The following is a description of a gene set: studied in species Homo sapiens Human Gene Set: YANG_BREAST_CANCER_ESR1_DN from publication Yang F, Foekens JA, Yu J, Sieuwerts AM, Timmermans M, Klijn JG, Atkins D, Wang Y, Jiang Y (PMID 16261164) Genes down-regulated in early primary breast tumors expressing ESR1 vs the ESR1 negative ones. About 70-80% of breast cancers express estrogen receptor alpha (ER-alpha), and estrogens play important roles in the development and growth of hormone-dependent tumors. Together with lymph node metastasis, tumor size, and histological grade, ER status is considered as one of the prognostic factors in breast cancer, and an indicator for hormonal treatment. To investigate genes and pathways that are associated with ER status and epithelial cells in breast tumor, we applied laser capture microdissection (LCM) technology to capture epithelial tumor cells from 28 lymph node-negative breast tumor samples, in which 17 patients had ER-alpha+ tumors, and 11 patients have ER-alpha- tumors. Gene expression profiles were analysed on Affymetrix Hu133A GeneChip. Meanwhile, gene profiles using total RNA isolated from bulk tumors of the same 28 patients were also generated. In total, genes and genes with significant P-value and having significant differential expression between ER-alpha+ and ER-alpha- tumors were identified from the LCM data set and bulk tissue data set, respectively. A total of genes were found to be common in both data sets, while genes were unique to the LCM data set and genes were present only in the bulk tumor data set. Pathway analysis with the genes using Gene Ontology suggested that genes involved in endocytosis, ceramide generation, Ras/ERK/Ark cascade, and JAT-STAT pathways may play roles related to ER. The gene profiling with LCM-captured tumor cells provides a unique approach to study epithelial tumor cells and to gain an insight into signaling pathways associated with ER., and this is the list of marker genes: SLC25A37, FABP5, YEATS2, RAP2B, SFRP1, LDHB, SLC9A6, GABRP, TUBB6, CDH3, PLCH1, BCL11A, BTG3, MFAP2, PUM3, LBR, TBX19, SOX11, ARHGEF9, RARRES1, PROM1, CYB5R2, TLE4, TRIM2